The following is a description of a gene set: studied in species Homo sapiens Human Gene Set: HP_ABNORMAL_CIRCULATING_FREE_T4_CONCENTRATION Abnormal circulating free T4 concentration A deviation from the normal concentration of free thyroxine (T4) in the blood circulation. Circulating T4 is almost entirely bound to specific transport proteins such as thyroxine-binding globulin (TBG) but it is the unbound (free) fraction that is able to enter tissues and exert effects., and this is the list of marker genes: THRB (NCBI Gene Id 7068), NKX2-5, TBL1X, SECISBP2, CPE, MADD (NCBI Gene Id 8567), POU1F1, IRS4, ALB, KCNJ18